The following is a description of a gene set: studied in species Homo sapiens Reactome Pathway: Nef mediated downregulation of CD28 cell surface expression part of: Nef-mediates down modulation of cell surface receptors by recruiting them to clathrin adapters Down-regulation of CD28 receptors involves a dileucine-based motif in the second disordered loop of Nef, which connects Nef to adaptor protein (AP) complex, which is a part of cellular endocytosis machinery. Nef induces accelerated endocytosis of CD28 via clathrin-coated pits followed by lysosomal degradation., and this is the list of marker genes: AP2M1, nef, CD28